The following is a description of a gene set: Mouse Gene Set: GOBP_PROTEIN_K48_LINKED_DEUBIQUITINATION studied in species Mus musculus A protein deubiquitination process in which a K48-linked ubiquitin chain, i.e. a polymer of ubiquitin formed by linkages between lysine residues at position 48 of the ubiquitin monomers, is removed from a protein., and this is the list of marker genes: Tnfaip3, Usp27x, Usp14, Usp19 (ubiquitin specific peptidase 19), Park7, Usp37, Usp25 (ubiquitin specific peptidase 25), Atxn3, Vcpip1, Otub2, Usp29, Ubxn1, Usp8, Otud5, Otud3, Mindy3, Usp34, Mindy4, Usp5, Otub1, Otud7b, Otud4, Usp20, Bap1, Usp33, Yod1, Usp17le